Given this list of marker genes SIRT7, KHDC3L, KAT7, ACTR5, SMCHD1, SHLD3, CREBBP, TERF2, RNF169, CCDC117, SMARCD2, SLF2, ABRAXAS1, C11orf54, FBH1, WRAP53, SMARCE1, SUV39H1 (SUV39H1 histone lysine methyltransferase), SETD2, WDR48, SPIRE1, RECQL5, CDK9, KDM1A, SGF29, KLHL15, RMI2, POLH, TADA3, UBE2V2, UBE2V1, TAF7, INO80E, EGFR, SENP3, NFRKB, TIGAR, PELI1, BCL7A, DDX11, PARPBP, YY1, WAS, AGER, RIF1 (replication timing regulatory factor 1), FAM168A, KMT5B, TERF2IP, KMT5A, PIAS4, TAF6, KAT5, POT1, CHEK1, INO80C, SUPT7L (SPT7 like, STAGA complex subunit gamma), FANCB, TADA2B, MAGEF1, EPC2, NBN, RNF8, ATM, PHF10, UBQLN4, TAF2, RAD50, RPA2, BCL7B (NCBI Gene Id 9275), ATR, TWIST1, FMN2, DPF3, PML, SMARCB1, ERCC8, VPS72, PBRM1, PNKP, OTUB1, PRKDC, TAF12, TRIM28, CYREN, DHX9, SMARCC1, HMGB1 (NCBI Gene Id 3146), FIGNL1, ZCWPW1, BCL7C, KDM4D, PRKCG, CGAS, KMT5C, CEBPG, FGF10, TIMELESS, MORF4L2, TADA1, PARP3, ACTR2, SKP2, RAD51AP1, HELQ, IER3, RAD51, KAT2B, TAF10, NUDT16L1, SUPT3H, RNF126, CBX8, MARCHF6-DT, EYA2, RIOX1, TP53BP1, INO80B, SIRT1, PARP1 (NCBI Gene Id 142), NPAS2, TRRAP, ERCC6, ACTB, INO80D, PPP4R3A, ACTL6A, EPC1, SETD7, SPIDR, BRCA1, FUS, USP51, PPP4R3B, SLF1, ARID1B, USP1, INO80, RTEL1, C1QBP, YEATS4, SF3B3, BRD7, SMARCC2, MIR221, MAD2L2, TAF4, SETMAR, DPF2, MRNIP, TEX15, PPP4R3C, AUNIP, EP400, TMEM161A, XRCC1, SMARCA2, RPS3, EYA4, STK19, TOP2B (NCBI Gene Id 7155), UIMC1, PPP4C, PRMT1, DPF1, MRE11, OOEP, ATXN7L3, CSNK2A1, KAT2A, HDGFL2, HSF1, ABL1, CUL4A, TFPT, HELB, SMARCD3, SF3B5, BRCC3, ACTR8, BARD1, HMGA2 (NCBI Gene Id 8091), MRGBP, RUVBL1, FOXM1, RAD52, RNF168, PPP4R2, UCHL5, AXIN2 (NCBI Gene Id 8313), TAF5, RADX, ATRIP, TFIP11, TAF5L, BRD8, DMAP1, PCNA, SIRT6, OGG1 (8-oxoguanine DNA glycosylase), SPIRE2, SMARCA4, MORF4L1, ENY2, HDAC10, ARID1A (AT-rich interaction domain 1A), FH, SHLD2, ING3, PLK1, SMARCD1, NSD2, MBTD1, TAF6L, BABAM1, ARID2, ATXN7, MCRS1, PARG, EYA1, EYA3, MGMT, RUVBL2, SHLD1, POLQ, TAF9, MEAF6, H2AX, ZNF365, ACTL6B, SUPT20H, BABAM2, DEK, UBE2N, USP22, here is a description of the gene set: studied in species Homo sapiens Any process that modulates the frequency, rate or extent of DNA repair. Human Gene Set: GOBP_REGULATION_OF_DNA_REPAIR